The following is a description of a gene set: from publication Doering TA, Crawford A, Angelosanto JM, Paley MA, Ziegler CG, Wherry EJ (PMID 23159438) studied in species Homo sapiens During acute viral infections, naïve CD8+ T cells differentiate into effector CD8+ T cells and, after viral control, into memory CD8+ T cells. Memory CD8+ T cells are highly functional, proliferate rapidly upon reinfection and persist long-term without antigen. In contrast, during chronic infections, CD8+ T cells become “exhausted” and have poor effector function, express multiple inhibitory receptors, possess low proliferative capacity, and cannot persist without antigen. To compare the development of functional memory T cells with poorly functional exhausted T cells, we generated longitudinal transcriptional profiles for each. Human Gene Set: GSE41867_DAY15_EFFECTOR_VS_DAY30_MEMORY_CD8_TCELL_LCMV_ARMSTRONG_UP Genes up-regulated in CD5 T cells at acute infection with LCMV-Armstrong: effectors at day 15 versus memory at day 30., and this is the list of marker genes: TMEM140, RAD9B, TIPARP, SNORC, ENPP1, KCNK13, MPV17, ACCS, JHY, CCL13, SCAF4, FIGNL1, CSF3, C15orf39, TRIT1, LYRM2, SRPK2, GNL2, GCNT2, TRMT2B, IL10, UMAD1, VSTM2A, ZFYVE9, WDR4, SNX15, THADA, SNX16, ZDHHC18, SPATA6L, TIMM8A, RAI2, BCAM, SLAMF8, OSM, ZFAND5, CAMK2N2 (calcium/calmodulin dependent protein kinase II inhibitor 2), TMEM100, ABHD5, GZF1, SMCR8, CHRNA2, VPS18, LINC00612 (long intergenic non-protein coding RNA 612), MARVELD2, ABHD1, HILPDA, RGL1, CERT1, KCNB1, MNAT1, RCBTB1, FGD6, JMJD1C, NT5DC3, B4GALT4, ZFAND2A, HBEGF (heparin binding EGF like growth factor), STAM2, ZGLP1, BCAR3, MYO16 (NCBI Gene Id 23026), GRAMD2B, SLC6A8, KLF9, SNX30 (NCBI Gene Id 401548), GNL3, ZNF23, DIAPH3, FNIP2, ARID1B, GLT6D1, ZNF131, CALML5, CSRNP1, RALGDS (NCBI Gene Id 95849), BMP7, DTX4, P2RY1, PTTG1IP, SRSF11, EMP1, PRMT9, SH3BP5 (SH3 domain binding protein 5), SAMD8, PRMT8, SH3TC1, GLA, PBDC1, MAFK, PDE2A (NCBI Gene Id 5138), NIP7, HPS5, ATP6V1C1, NR2E1, ST6GALNAC4, ANKRD12, COMTD1, GPRIN2, SPATA1, C12orf75, DUSP4, FAM110B, RAPH1, GAS2L3, BACH1, KCNK4 (NCBI Gene Id 50801), NEIL1, DHPS (deoxyhypusine synthase), ZNF655, CPEB4, TBC1D8B, RRAGC, ZC4H2, KRTAP4-3, RABGAP1, ATP13A3, SIRT2, PLA2G2E, ALDH3A1, OSER1, IL31RA, CDK2, RCHY1, BHMT2, CCNF, RPE65, RGS1, MDM2, YBX2, ELANE (NCBI Gene Id 6417), CALML4, CABLES1, INAFM1, PEDS1, PIP4P1, ZFP36L2, LAMTOR3, RABGEF1, SLC5A11, LOXL2, ME3, USP6NL, RTP3, SPTY2D1, LMO3, ABCG2, TANC1, TNFSF14, CLN8, TMEM121, SPHK1, RARRES1, DCST1, TLE4 (TLE family member 4, transcriptional corepressor), CYFIP2, ZNF541, SLC38A3, LONRF3, CLRN3, VPS26A, SPR, THAP6, N4BP2L2, NOXRED1, SH3RF1, SLC2A9, TRMT5, ZMIZ1, OPTN (optineurin), NAF1, FBXW7, GPRC5A, SOX15, AJUBA, TRAF3, METTL17, MAFB, DTX2, PCYT1A, TIA1, IFITM5, TLR3, GPR146, SNORD89, FEM1B, RHOV, ABL2, POGK, PGAP3, KDM7A, CEP170, MESP2, SRL, ACVR1C, PRCP, FEM1C, LRATD1, APOD (NCBI Gene Id 347)